Given this list of marker genes PTPRR, ADAM28, ABCB4, EEF1G, PEX2, S100A10, NDN, CALM3, PLA2G7 (phospholipase A2 group VII), PSMC3, MYH2, PPP3CC, BMP8B, TST, GFER, TNFRSF4, APBB2, POLA2, CLTB, IL6ST, PSMB8, RAI2, WNT4, DBP, COL1A1, PPP1R2, HSPA8, USP50, SIN3A, LONP1, COL3A1, COL1A2, NR2F1, USP4, PHOX2A, PMP22, PRKCSH, CDK11B, ZNF32, FDFT1, here is a description of the gene set: The gene expression profile of the aging process was analyzed in skeletal muscle of mice. Use of high-density oligonucleotide arrays representing genes revealed that aging resulted in a differential gene expression pattern indicative of a marked stress response and lower expression of metabolic and biosynthetic genes. Most alterations were either completely or partially prevented by caloric restriction, the only intervention known to retard aging in mammals. Transcriptional patterns of calorie-restricted animals suggest that caloric restriction retards the aging process by causing a metabolic shift toward increased protein turnover and decreased macromolecular damage. Human Gene Set: LEE_AGING_MUSCLE_DN Downregulated in the gastrocnemius muscle of aged adult mice (30-month) vs young adult (5-month) from publication Lee CK, Klopp RG, Weindruch R, Prolla TA (PMID 10464095) studied in species Mus musculus